Given this list of marker genes Pop7, Rpp40, Pop5, Rpp38, Pop1 (processing of precursor 1, ribonuclease P/MRP family, (S. cerevisiae)), Rpp30, Rpp21, here is a description of the gene set: species: Mus musculus Mouse Gene Set: GOCC_NUCLEOLAR_RIBONUCLEASE_P_COMPLEX A ribonuclease P complex located in the nucleolus of a eukaryotic cell, where it catalyzes the 5' endonucleolytic cleavage of precursor tRNAs to yield mature tRNAs. Eukaryotic nucleolar ribonuclease P complexes generally contain a single RNA molecule that is necessary but not sufficient for catalysis, and several protein molecules.